Given this list of marker genes TCF4, COG4, PRKACA, MAPKAPK5, SIN3A, TGFB3, ATN1, METTL5, here is a description of the gene set: studied in species Homo sapiens Positioning of the nasal tip inferior to the nasal base. Human Gene Set: HP_OVERHANGING_NASAL_TIP Overhanging nasal tip